The following is a description of a gene set: species: Homo sapiens Human Gene Set: chrXq24, and this is the list of marker genes: NKRF, HSPA8P1, LAMP2, RHOXF2B, ZBTB33, RPL12P43, CT47A8, NKAP, RHOXF1-AS1, RHOXF1P2, RNU7-37P, NKAPP1, SLC25A5-AS1, C1GALT1C1, RNU1-67P, MCTS1, PA2G4P1 (proliferation-associated 2G4 pseudogene 1), CT47A2, RPL39, NDUFA1, SOWAHD, SLC25A43, ATP1B4, CT47A10, MIR1277, CT47A3, CT47A5, H3P46, RNY3P16, WDR44, KLHL13, SLC25A5, UBE2A, LINC03098 (NCBI Gene Id 101928336), TMEM30BP1, AKAP17BP, ZCCHC12, CT47A9, RBBP8P1, TMEM255A, CT47C1, AKR7A2P2, PGRMC1, ENSG00000239182, HNRNPA1P28, CT47B1, AKAP14, RHOXF1, ENSG00000300121, CT47A6, CUL4B, RN7SL118P, CT47A1, GLRX5P1, MRPS17P9, STEEP1, DOCK11, ARL5AP1, CBLL1P1, IL13RA1, COBLP1, CT47A4, MIR766, NUDT19P6, KIAA1210, RHOXF1P1, LINC01285, UPF3B (UPF3B regulator of nonsense mediated mRNA decay), CT47A7, MIR3672, RHOXF2, EEF1A1P30, SFR1P1, CT47A12, LONRF3, CT47A11, GLUD2, RNF113A, TUBB4BP3, SNORA69, SEPTIN6, RHOXF1P3